Given this list of marker genes CHRM3, LINC00871, SLC43A2, DHTKD1, ARHGAP26, FKBP5, MOGAT1, CAMK4, PRKAG2, OSBPL1A, SLC13A1, MFSD4B, ASPSCR1, KAT6B, SLC1A1, EPS8L2, CLTC, OPTN, CTNNA3, SLC5A12, HPN, SUCLG2-DT, ZNF826P, C11orf65, RGN, CCDC191, PTH1R, PCK1, ULK4, ANKS1B, BBS9, PPP6R2, SHANK2, KIAA1671, PIP5K1A, ACSM2B, KIFC3, DMD, TNS1, MAL2, AFM, FRAS1, PAQR5, LINC00276, LINC01322, ZFC3H1, NCOR1, ASPA, TEX36, KCNK5, BHMT (NCBI Gene Id 83323), RBM25, RNF152, SLC16A9, SHROOM4, PRODH2, MAOB, GACAT3, EBNA1BP2, PPARA, ITSN1, ACIN1, LENG8, USP8, GOLGB1, TNRC6C, EPHA8, CTSH, SLC13A3, GTF2IRD1, BAZ1B, SRRT, SLC7A7, SLC26A3, C19orf12, CCDC149, SUCLG1, SRSF11, KMT2B, ZNF804B, LRRC4C, DRD3, LINC01060, PCDH15, ROBO2 (NCBI Gene Id 90370), TFDP2 (NCBI Gene Id 7029), SPPL3, PIGL, FAM227B, STX8, NRG1, TAPT1-AS1, ZHX3, TENM2, RBM6, GON4L, ASS1, SLC4A4, NCKAP5, GADD45A, BICDL1, AKAP13, TBCA, RASSF4, GPX3, CACNA1C, ASTN2, ZNF91, MLXIPL, PRKCE, PAX8, SMIM24, TPD52, CYTH1, KDM2A, LINC01255, TMEM232, NQO2, GNGT2, WDR19, UPB1, GHR, TCF25, NFE2L1, BRD9, COL4A1, CREBBP, URGCP, BCOR, SLC22A12, UBE4B, DAB1, FXR2, RAB11FIP3, ARHGAP10, RORA, EOLA2-DT, ABCC2, CYP2R1, SHISA6, PRLR, EOLA1-DT, SLC22A7, CRYL1, MMP15, TOB2, AHI1-DT (AHI1 divergent transcript), TRA2B, UPP2, OGA, CCND3, ECHDC2, P4HA1, LINC00671, AIG1, PAX2, LINC00907, GRIN2B, LINC00635, CHD2, GRAMD1B, ACSM2A, WIPF1, ENOX1, RBM39, SLC16A12, ZNF614, ENPP6, ATXN7L1, DOK6, LMCD1-AS1, CSMD2, PCSK5 (NCBI Gene Id 96284), TANC2, SLC17A1, AFMID, RNA5SP475, NRSN2-AS1, CLUAP1, ANPEP, PRPF38B, SLIT3, NRP1, SAFB2, HNF1A-AS1, RUNX1, EIF5B, CFAP46, PRSS51, DPP10, SLC7A8, ADD1, LUC7L, MCTP1, ALDOB, POR, EYA2, TNRC6A, YTHDC1, SIPA1L3, PAPPA2, DIP2B (disco interacting protein 2 homolog B), LINC01515, CDON, C4orf19, SLC2A9, SCAF8, PLCG2, FGD4, FGGY, CUBN, NSMF, PRKRIP1, TNRC6B, DZIP1, AGPAT3, PRRC2C, CDR2, ACACB, EGR1 (early growth response 1), DEPTOR, CUX1, CNTN4, PRICKLE2, PDE4D, TTTY14, LINC01239, FRMD6-AS2, SORCS1, SAMD5, EPHX2, ALDH6A1, RNF212B, C9orf85, RIN2, MIOX, SLC22A11, PHF14, IL36B, ZBED3-AS1, NSUN6, PTPRG, MYRIP, BCL2, KCNJ15, NUMB, PDHX, PLG, DPH6, GABBR2, NFIX, PLEKHA5, DCC, PLEKHA7, SEMA4D, NR6A1, HOOK2, PPP1R21, PPP1R16B, LINC00402, XPC, WDR13, ARID4A, GCNT2, SLC36A2, MET, PDE10A (NCBI Gene Id 90632), TMEM63A, KIF26B, SLC47A1, MYO6, MME, LSAMP, RASGEF1B, SRRM2, SORBS2, NELL1 (NCBI Gene Id 4745), SPEF2, AGMO, DHRS3, CMBL, LUC7L3, FSIP1, PARP10, HMGB1, MARK2, LIN52, TMEM214, ENOSF1 (NCBI Gene Id 55556), PLEKHA6, IGF2BP2, TTC23L, USH1C, PTMS, KIAA1549, CSMD1, ZC4H2, ARHGAP42, RIMS2, TRABD2B, MACROD2, UPF3B, ATP2A2, NFKBIA, ADAMTS8, IL1RAPL2, RHOBTB1, PPP2R5E (NCBI Gene Id 63385), PGPEP1 (NCBI Gene Id 83542), SLC16A10, OTUD7A, LARGE1, AK4, TCEA3, SMG6 (SMG6 nonsense mediated mRNA decay factor), EMX2OS, ZBTB16, COL27A1, SREK1, PFKL, MAP3K13, GLIS1, DNAH2, OPHN1, NHS, CACNA1D, TENM4, HIP1, SUGCT, TLN2, HECW1, CRADD, MIR100HG, GALM, RAPGEF3, ANK1, FMN1, SLC28A1, SLC39A11, ADGRV1, NFIC, TMT1A, MAPT, TENT5A, CHD6, AP3D1, THOC2, CSPP1, BAZ2A, PHF20, LARP1, PDZD2 (NCBI Gene Id 23037), RNF220, ASXL1, ABAT, UNC13B, LINC03124, ZC3H13, ZNF708, SMARCC1, KIF12, CYP3A5, ITCH, LRFN2, DPYS, TPCN1, RNF115, LRP2, FRMD3, SRPK2, CYP4A22-AS1, AQP4-AS1, RBM47, R3HDML-AS1, ACSF2, DNM1, BNIP3L, CFDP1, MDN1, BTNL10P, UPF2, DYNC2I1, DLG2 (NCBI Gene Id 283225), ZC3H6, RGL3, PNISR (PNN interacting serine and arginine rich protein), SMIM2-AS1, AGXT2, LINGO1, CCAR1 (cell division cycle and apoptosis regulator 1), AK9, ZMAT1, GUSBP11, TIMM23B, NT5C2, INSR, SLC22A6, FRMD4B, TRPM3, VDR, MSRA, KLHDC8A, CNTNAP2, FRMD4A, DNM2, RRH, GMDS-DT, PPM1L, FOS, PRUNE2, ANKRD11, SNX29, UBN1, GAS5, BRD4, CNTN1, WWOX, here is a description of the gene set: studied in species Homo sapiens from publication Lake BB, Chen S, Hoshi M, Plongthongkum N, Salamon D, Knoten A, Vijayan A, Venkatesh R, Kim EH, Gao D, Gaut J, Zhang K, Jain S (PMID 31249312) Human Gene Set: LAKE_ADULT_KIDNEY_C5_PROXIMAL_TUBULE_EPITHELIAL_CELLS_STRESS_INFLAM